The following is a description of a gene set: Human Gene Set: REACTOME_NUCLEAR_EVENTS_KINASE_AND_TRANSCRIPTION_FACTOR_ACTIVATION Nuclear Events (kinase and transcription factor activation) species: Homo sapiens, and this is the list of marker genes: TCF12, PPP2R1B, PPP2CA, CREB1, PPP2R5D, FOS (NCBI Gene Id 2353), CDK5R2, SGK1, CDK5R1, TPH1, EGR3, VGF, PPP2CB, ELK1, MAPK7, NAB1, EP300, ID4, LYL1, REST, PPP2R1A, DUSP7, ID1 (inhibitor of DNA binding 1), FOSB, ATF1, MAPKAPK2, MAPK11, MAPK3, CDK5, EGR4, MEF2D, RPS6KA1, SRF, EGR2, MAPK1, ASCL1, DUSP4, RRAD, CHD4, MEF2C, RPS6KA5 (ribosomal protein S6 kinase A5), MAPK14, NAB2, F3, ID3, ARC, RPS6KA3, EGR1, DUSP3, JUNB, ID2, RPS6KA2, DUSP6, DNM2, VRK3 (NCBI Gene Id 51231), ATF2, JUND, SH3GL3 (SH3 domain containing GRB2 like 3, endophilin A3), FOSL1, MEF2A, TRIB1